The following is a description of a gene set: Genes in the cancer module 426. studied in species Homo sapiens Human Gene Set: MODULE_426, and this is the list of marker genes: ELF3, PRG2, SLC26A8, APOC1, NUCB2, MLANA, PYROXD1, DIABLO, HBZ, CNTNAP1, CYP26B1, MAL2, PCSK1, SERPINA6, HGD, CD151, TCN2, HLA-DPB1, MAPK4, RRAD, BCHE, MAP7, CEBPD, TFAP2A, RPS6KL1, SPI1 (Spi-1 proto-oncogene), NPY1R, CNRIP1, CYP3A5, CLDN10, PHYHIP, SYBU, SHBG, XK, S100P, SLC19A1, CFAP410, ARAP2, DDC, COL13A1, SCN3B, CSPG5, SMOC2, APCS, ITGB4, MS4A7, CEACAM6, SHROOM2, TBC1D23, ISG20, UGT2B4, SLC2A9, ITIH5, KCNS1, RPL27A, WDCP, SRPX, ACVRL1, FTH1, F5, MBL2, EPHX1, AGBL5, KIF5C, LACTB2 (lactamase beta 2), CDH5, TNIP3, BCAN, SPHK2, TKTL2, PPP1R14C, GAS6, SIRT6, SLC8A2, ALOX5, DYNC1I1, MLC1, IGSF3, SST, WT1, ZIC4, CHN2 (chimerin 2), SPNS1, TSPAN1, FSCN1, SLC17A1, KLRC3, FZD2 (NCBI Gene Id 2535)